The following is a description of a gene set: Human Gene Set: GOBP_REGULATION_OF_ANIMAL_ORGAN_MORPHOGENESIS studied in species Homo sapiens Any process that modulates the frequency, rate or extent of animal organ morphogenesis., and this is the list of marker genes: APCDD1, SULF1, VANGL2, TNF, SFRP2, BMP2, BMP7, SEC24B, AGT, FGF2, CAV3, PHB2 (prohibitin 2), SOX9, SAPCD2, FRS2, GDNF, PAX8, NTN4, NOG, HOXB7, FGF1, TNFRSF11B, DMRT3, PAX9, AGTR2 (angiotensin II receptor type 2), AHI1, WNT2, NGFR, FGF10, STOX1, WNT3A, WT1, CITED2, HOXC11, WNT2B, WNT4, BMPR1A, CD34, SNAI2, FGF8, MSX1, HGF, RSPO2, ROBO2, TACSTD2, AJAP1, MAGED1, FGFR1, SMO, HOXA11, POU5F1, GREM1, SP6, CTNNB1, TBX1, SIX2, VEGFA, SIX1, MESP1, GATA5, SOX8, GATA3, BTBD7, SHH, WNT5A (Wnt family member 5A), SIX4, SPRY1, DKK1, RUNX2, LHX1, JHY, TGFB1, ETV5, PDGFA, CSF1, LGR4, PKHD1, SFRP1, ROBO1, BMP4, AR, WNT10A, EDN1, FGF7